The following is a description of a gene set: studied in species Homo sapiens Human Gene Set: GOBP_PHOSPHATIDYLGLYCEROL_BIOSYNTHETIC_PROCESS The chemical reactions and pathways resulting in the formation of phosphatidylglycerols, any of a class of phospholipids in which the phosphatidyl group is esterified to the hydroxyl group of glycerol., and this is the list of marker genes: CDS2, PTPMT1, TAMM41, PGS1, GPAM, CRLS1